The following is a description of a gene set: Mouse Gene Set: TABULA_MURIS_SENIS_LUNG_MATURE_NK_T_CELL_AGEING from publication Tabula Muris Consortium (PMID 32669714) studied in species Mus musculus, and this is the list of marker genes: Rgs1, Slc3a2, Cd3g, Camk2n1, Serpina3g, Rps15a, Tspan13, Rpl3, Cst7, Cd3e, AW112010, Sh2d1a, Ctla2a, Ctsb, Glrx, Rps9